The following is a description of a gene set: Mouse Gene Set: GOMF_OPIOID_PEPTIDE_ACTIVITY Naturally occurring peptide that is an opioid (any non-alkaloid having an opiate-like effect that can be reversed by naloxone or other recognized morphine antagonist). These include Leu- and Met-enkephalin, dynorphin and neoendorphin, alpha, beta, gamma and delta endorphins formed from beta-lipotropin, various pronase-resistant peptides such as beta casamorphin, and other peptides whose opiate-like action seems to be indirect. species: Mus musculus, and this is the list of marker genes: Zfp106, Pdyn, Penk, Cdc42ep2, Pnoc